Given this list of marker genes MMP13, COL9A2, ACAN, SMAD3, SMAD2, LMX1B (NCBI Gene Id 4010), ORC1, here is a description of the gene set: A joint disorder caused by blood deprivation in the subchondral bone causing the subchondral bone to die in a process called avascular necrosis. The bone is then reabsorbed by the body, leaving the articular cartilage it supported prone to damage. The result is fragmentation (dissection) of both cartilage and bone, and the free movement of these osteochondral fragments within the joint space, causing pain and further damage. Human Gene Set: HP_OSTEOCHONDRITIS_DISSECANS Osteochondritis dissecans species: Homo sapiens